Given this list of marker genes C3AR1 (complement C3a receptor 1), C5AR2, C5AR1, CR1, CD14, here is a description of the gene set: Combining with an opsonin and transmitting the signal from one side of the membrane to the other to initiate a change in cell activity. studied in species Homo sapiens Human Gene Set: GOMF_OPSONIN_RECEPTOR_ACTIVITY